Given this list of marker genes TMEM200A, METTL23, IER5, MED13, ROBO1, ARAF, TGFBR1 (NCBI Gene Id 7046), TOR1AIP1, RIOX2, BMP4, DNAJC6, CNRIP1, SECISBP2L, TYW3, HACE1, TRPC4, ANLN, here is a description of the gene set: from publication Chen Y, Wang X (PMID 31504780) species: Homo sapiens Genes predicted to be targets of miRBase v22 microRNA hsa-miR-6082 in miRDB v6.0 with MirTarget v4 prediction scores > 80 (high confidence targets). Human Gene Set: MIR6082